The following is a description of a gene set: Binding to a protein upon methylation of the target protein. studied in species Mus musculus Mouse Gene Set: GOMF_METHYLATION_DEPENDENT_PROTEIN_BINDING, and this is the list of marker genes: Cbx2, Spin2-ps3, Gm20873, Spin2-ps4, Zzz3, Gm20773, Zcwpw1, Kdm4a, Atrx, Spin2e, Gm21719, Morc4, Glyr1, Msl3, Gm20737, Gm20821, Spin1, Suz12, Ncapd3, Phf20l1, Spin2-ps7, Spin2-ps8, Pygo1, Phf1, Gm20806, Fmr1, Cxxc1, Zmynd11, Gm20816, Dppa3, Gm20747, Mphosph8 (M-phase phosphoprotein 8), Gm20830, Kdm7a, Ing4, Cbx1, Zmynd8, Gm21118, Spin2j, Chd1, Rag2, Kmt2e, Gm20807, Gm28171, Morc3, Gm20834, L3mbtl1, Gm20795, Gm21854, Gm20918, Gm20865, Rrp8, Spin2d, Gm20808, Gm20812, Mtf2, Gm20914, Gm20854 (predicted gene, 20854), Bptf, Jmjd7, Gm21394, Ing5, Kdm5a, Ssty1 (NCBI Gene Id 20835), Spin2g, Msh6, Zzef1, Trp53bp1, Hdgfl2, Gm20917, Sgf29, Phf19, Gm21310, Ing2, Gm20818, Spin2c, Spin2-ps10, Ssty2, ENSMUSG00000121958, Pwwp2a, Phf2, Cbx6, Spin2h, Chd8, Zcwpw2, Phf8, Spin2-ps1, L3mbtl3, Spin2-ps2, Gm20826, Spin2-ps9, Gm20822, L3mbtl2, Tdrd3, Uhrf1, Gm20852, Cdyl, Lrwd1, Wdr5, Setd5, Gm21812, Eed, Ing3, Gm20815, Gm20738, Cbx8, Cbx5, Mbtd1, Gm21292, Cdyl2, Gm20825, Cbx3, Ncapg2, Phf13, Ing1 (inhibitor of growth family, member 1), Kdm8, Thap7, Spin4